Given this list of marker genes Pfn1 (NCBI Gene Id 18643), Eps8, Carmil2, Cav1, Sh3yl1, Plekhm1, Def8, Evl, Aif1, Hras, Mtor, Eps8l1, Pfn2, Inppl1, Cobl (NCBI Gene Id 211381), Rcc2, Ndel1, Coro1c, Bag4, Arhgef26, Stap1, Ston1, Icam1, Pip5k1a (NCBI Gene Id 18720), Inpp5k, Pdgfrb, Arf6, Snx10, Nlgn1, Rhog, Aif1l, Tacstd2, Rac1, Cyfip1, Wdpcp, Cspg4, Usp17le, P2ry12, Kank1, Eps8l3 (NCBI Gene Id 99662), Fam98a, Arhgap24, Eps8l2, Sh3bp1, Rdx, here is a description of the gene set: The aggregation, arrangement and bonding together of a set of components to form a ruffle, a projection at the leading edge of a crawling cell; the protrusions are supported by a microfilament meshwork. The formation of ruffles (also called membrane ruffling) is thought to be controlled by a group of enzymes known as Rho GTPases, specifically RhoA, Rac1 and cdc42. Mouse Gene Set: GOBP_RUFFLE_ASSEMBLY studied in species Mus musculus